Given this list of marker genes EDNRA, MYH10, ADPRHL1 (NCBI Gene Id 400169), FHL2, COL11A1, PTK7, KCNJ8, NSD2, TNNI3, MIR17HG, SLIT3, HECTD1, SMAD6, PARVA, OVOL2, SLIT2, NPHP3, MKS1, HAND2, NPY2R, TBX1, FOXC1 (NCBI Gene Id 3666), DCTN5, SHOX2, TGFBR2 (NCBI Gene Id 7048), SCN5A, MYOCD, RBP4, TMEM65, TGFB2, BMP4, CNTRL, FOXF1, NPRL3, FGFR2, HES1, SAV1, SRF, GATA3 (NCBI Gene Id 84828), NRP1 (neuropilin 1), DHRS3, SALL4, TNNC1, HIF1A, CCN1, LMO4, ANK2 (ankyrin 2), MATR3, PKP2, BMP7, TAB1, MYH7, SMAD7, PLXND1, WNT11, BMP2, SUFU, FGFRL1, SMAD4, CAV3, SNX17, ZMPSTE24, TNNI1, PRDM1, MEF2C, ROBO2, FOXC2, MYH6, TRIP11, HEY2, SMO, MESP1, MYL3, EVA1A, TP53, ACVR1 (NCBI Gene Id 90), TGFBR1, CRELD1, TPM1, ADAMTS19, FRS2, SEMA3C, NRG1, ID2, TGFB1, NOTCH2 (NCBI Gene Id 55574), DSP, NOS3, RARB, VANGL2, ADAMTS1, PITX2, GATA6, NRP2, NOG, PPP1R13L, PAX8, PTCD2, POU4F1, SFRP2, MED1, EGLN1, ISL1, MDM4, GATA4, MYBPC3, FGF8, ZFPM2, HAND1, CPE, GJA5, STRA6, ENG, KCNK2, ROBO1, SALL1, MIR1-1, MYL2, DAND5, ZFPM1, ZBTB14, BMPR2, CITED2, PDE2A, FZD2, GREB1L, DNAH11, HEYL, ADGRG6, WNT2, GSK3A (NCBI Gene Id 2931), XIRP2, SOX11, NACA, NDST1, LRP2, SOS1, ADAMTS6, SOX4, FKBP1A, JAG1, NKX2-5, HOXA13, FOXH1, CHD7, RARA, TGFBR3, RYR2, PROX1, MSX2, APLNR, HEY1, MDM2, NAGLU, TBX2, MAML1 (mastermind like transcriptional coactivator 1), BMP5, UBE4B, RBM15, LUZP1, TEK, TBX3, DLL4, TBX5, TNNT2, GRHL2, SMARCD3, TBX20, FZD1, BMP10, NOTCH1, NPY5R, HEG1 (heart development protein with EGF like domains 1), AP2B1, WNT5A, RBPJ, BMPR1A, here is a description of the gene set: Human Gene Set: GOBP_CARDIAC_CHAMBER_DEVELOPMENT species: Homo sapiens The progression of a cardiac chamber over time, from its formation to the mature structure. A cardiac chamber is an enclosed cavity within the heart.